The following is a description of a gene set: Genes predicted to be targets of miRBase v22 microRNA hsa-miR-4672 in miRDB v6.0 with MirTarget v4 prediction scores > 80 (high confidence targets). Human Gene Set: MIR4672 from publication Chen Y, Wang X (PMID 31504780) studied in species Homo sapiens, and this is the list of marker genes: CEP70, ZNF84, SLC9A6, RBBP4, SLF2, KLF15, MINDY3, CARD9, GPATCH2L, RUFY3, ADAMTS15, DEF8, C1QTNF7, ZNF8, HOXA9, DYRK1A, EBF2, ADCYAP1, BAHCC1, ZFP36L1, USP34, GRIK2, HNRNPA1, SGTB, UBXN7, CTCF, RRM2, ABCC10, FOXF1 (forkhead box F1), STEAP2, STK24, ZNF597, KDM2A, TRA2B, NR3C1, TMEM108, MAP3K1, HIVEP1, KLHL9, NAP1L3, VAV3, MTMR9, GATC, PSIP1, MIER3, UBA6, STON1, TMTC4, SPRED2, HDHD2, HDAC1, VEPH1, INHBA, RAPGEF5, GUCY1B1, TLCD5, CASP10 (caspase 10), SDC2, RAB23, FAM184A, EYA4, NWD2, CRKL, TOP1, NSG1, SYNPO2L, NAP1L2 (NCBI Gene Id 4674), UBA2, ARHGEF33, PCNX1, HMGB1, WDR26, KIT, PAFAH1B1, ZDHHC15, LIMK1, GTF2H1, PMP22, C6orf136, FUT9, ZNF251, MMS22L, ZZZ3, RYBP, ACVR2A (activin A receptor type 2A), OTUD4, FAT4, ZNF711, LARP1B, SYBU (syntabulin), EYS, PCMT1, SREK1 (splicing regulatory glutamic acid and lysine rich protein 1), KHDRBS2, ARPC1B, SRSF10, SLCO1C1, CFAP97 (NCBI Gene Id 57587), SS18, SERTAD2, LRAT, RBPJ, ADGRG2, SEMA3C, ZYG11B, MAP3K8, ALG10B (ALG10 alpha-1,2-glucosyltransferase B), CCDC32, ZMAT3, EDIL3, MPDZ, MMRN1, TLX1, CLIP4, ABI1, ANKRD45, PPP4R2, TAF1, SLC35A1, PURB, NAA16, CLOCK, E2F5, ZNF385B, SNX12, ZIC2, FAM53C (NCBI Gene Id 51307), TSPYL5, AKAP11, AZI2, TMEM64, SORL1, DENND5B, RLIG1, RGMB, CACHD1, EBF1, STX7, NCOA4, WASF3 (NCBI Gene Id 10810), KCNA1, VMP1, STXBP5, CKAP2, DYRK2, LAMP2, CELSR3, DPY19L4, SGIP1, DLGAP4, NREP, GOLGA8B (NCBI Gene Id 440270), RFK, ZBTB14, ARID2, PWWP2A, ZNF148, MIPOL1, SYT1, CSNK1D (NCBI Gene Id 1453), LRRTM4 (NCBI Gene Id 80059), PTPRD, CEP72, DNAJC8, ZFHX3, GABRB2, PALLD, LNPK, JAG2, NSL1, HERC2, KCNJ16, CCDC62, CCDC112, RPN2, PHF13 (NCBI Gene Id 148479), TSHZ1, TOX, WDR47, KCNA4, SNX25, MRPS23, RFX4, GOLGA2, IKZF5, ABCA5, ARHGEF3, ZNF706, GTF2I (general transcription factor IIi), CANX, STK38, SEZ6L2, COLEC12, CAMKK2, KIF13A, CBX1, ZNF717, KIF5C, SLC16A14, TENM4, RCHY1, CLCN4, FLVCR1, FAT3, ZNF543, CELF2, L3MBTL2, PPP1CB, NALF1, KCNMB4, RNF216, SLC44A1, PAM, PRR18, AOX1 (NCBI Gene Id 316), LMO4, SAP30L, RAB8B, SASH1, SEC61A1, SRD5A1, ZNF623, HOPX, SNX30, MCTP2, LRRC59, PTBP3, DACT1, WDFY3, SLC20A1, ANKRD40, INPP5A, BCL9 (NCBI Gene Id 607), ZC3H6 (zinc finger CCCH-type containing 6), ACSL3, TSC22D1, DNM1L, GOLGA7, GOLGA6B, RIN2, C1orf21, LHFPL3, NLK, GOLGA6A, PLEKHA8, CTBP1, U2SURP, TPD52L1, GNAI1 (G protein subunit alpha i1), PTGFR, R3HDM1, CPSF6, UNC5C, PI15, VAT1L, RNF32, SMAP2 (small ArfGAP2), MECP2, AUNIP, UBE2K, WDR43, C6orf120, FBXO11, GOLGA6D, NKIRAS1, PCDH18, PPM1H, TNPO1, REV3L, GOLGA8A, SLC6A9, FBXO22, APC, ZEB1, GOLGA6L4, STUB1, UCK2, RHOA, HNRNPA0, CDC5L, FREM2, GRB2, CREM, ANTXR1, PRPF39, PEAK1, TMEM67, RAP2C, ZBTB41, PDZD8, ETV1, CEP68, NTF3, TBC1D12, CDYL2, RAB14, RAB31, NGFR, PAXBP1, FOXA3, PCBP1, ANXA7, UBR5, XG, TCP11L2, VPS4B, MGAT4A, DLG2, GABRA4, GAD2 (NCBI Gene Id 2572), SAFB, EDEM1, NPVF, MOSPD1, ESF1, PRRG1, LRRC8B, UBE2D2, FEM1B, EVI2A, HECTD4, PSD3, RHOB, SAMSN1, KANSL1 (KAT8 regulatory NSL complex subunit 1), DSC2, SGSM2, TSC22D2, ADGRV1, MOBP, MRAS, NPL, RAB6B, RTF1, WAC, PJA2 (praja ring finger ubiquitin ligase 2), WT1, RUNX2, SLC4A8, ADARB1, MAP4K4, CAV1, DIP2B, FAM53B, CDKN1B, RNF145, PLAGL1, ADNP, KLC1, IKZF2, MYRIP, LRCH4, GPBP1, EPSTI1, CRB1, LTBP1, EIF3J, MTRF1L, SENP6, FAM135B, SLC35F1, TM6SF1, ANKFY1, ERP44